Given this list of marker genes FBXW7, PTN, WNT3A, CEBPB, CUL3, LIMS2, RTN4, CFLAR, TNFAIP3, IL6, XBP1, GLI1, RPS6KA1, LIPA, PROX1, MDK, HPN, TGFA, NOTCH2, MED1, CEACAM1, SULF2, TNF, FGL1, here is a description of the gene set: The process in which the anatomical structures of the liver are generated and organized. Human Gene Set: GOBP_LIVER_MORPHOGENESIS species: Homo sapiens